The following is a description of a gene set: The establishment of epigenetic modifications (imprints) during gametogenesis, and propagation of these imprints during the organism's life. Genomic imprinting leads to an asymmetry between the maternal and paternal alleles and differential expression of the corresponding alleles. This can happen through heterochromatin formation or differential chromatin loop formation. Human Gene Set: GOBP_GENOMIC_IMPRINTING studied in species Homo sapiens, and this is the list of marker genes: DNMT3L, CTCF, NDN, ARID4B, CDKN1C, DIRAS3, CTCFL, PIK3CA, MECP2, GSK3A, ZFP57, DNMT3A, ZDBF2, MTA2, IGF2, TRIM28, MYCN, KDM1B, EED, PRMT7, ARID4A